Given this list of marker genes Hhex, Cdx2, Tbx3, Zic3, Nodal, Ripply2, Neurog1, Tmed2, Tdrd1, Ets2, Pcsk6, Mesp2, Frs2, Foxa2, Nrarp, Pgap1, Fzd5, Tbx6, Shh, Gdf3, Cripto, Aurka, Tdrd6, Bmp4, Hey1, Rnf2, Ldb1, Tdrd5, Ripply1, Lefty1, Cdx1, Nckap1, Prickle1, Wnt8a, Gpc3, Ctnnb1, Pld6, Tbx18, Kdm6a, Lhx1, Wnt5a, Tdrd7, Ski, Tasor, Smad4, Mesp1, Epb41l5, Hey2, Tifab, Wnt3, Lefty2 (NCBI Gene Id 98630), Tcf7l1, Otx2, Wls, Cdx4, Srf, Tdrkh, Cer1, Six2, Lrp6, Ddit3, Wt1, here is a description of the gene set: The establishment, maintenance and elaboration of the anterior/posterior axis. The anterior-posterior axis is defined by a line that runs from the head or mouth of an organism to the tail or opposite end of the organism. Mouse Gene Set: GOBP_ANTERIOR_POSTERIOR_AXIS_SPECIFICATION studied in species Mus musculus